The following is a description of a gene set: A phospholipid scrambling process that results in the appearance of phosphatidylserine on the outer leaflet of the plasma membrane of an apoptotic cell, which acts as an 'eat-me' signal for engulfing cells. Phosphatidylserine is exposed on the apoptotic cell surface by a phospholipid scramblase activity. studied in species Homo sapiens Human Gene Set: GOBP_PHOSPHATIDYLSERINE_EXPOSURE_ON_APOPTOTIC_CELL_SURFACE, and this is the list of marker genes: XKR8, XRCC4, FASLG, XKR4, XKR9, PLSCR1, XKR7 (NCBI Gene Id 343702), XKR6, TRPC5